Given this list of marker genes MYRF, KIF7, PPP1R15A (protein phosphatase 1 regulatory subunit 15A), TP53INP2, RELB, CLSTN3, FOS, SSTR2, C11orf87, SLC18A2, HDX, PLK4, KYAT1, PPIG, PTPRU, UBA52, NR4A2, RNF5, LETM2, PSMB8, ITFG2, GPBP1, DHX36 (NCBI Gene Id 96337), LSM12, PNMA6A, CRELD1, SYNGR3, JAG1 (jagged canonical Notch ligand 1), NUP98, MAFF, IRX3, AGPAT1 (1-acylglycerol-3-phosphate O-acyltransferase 1), SEMA4C, DUSP1, NDUFA10, WNT10A, ARL4D, RBP5, AKIRIN1, PFAS, MAP3K7, CMTR1, RAB24, HS3ST2, SLC38A1, PTGR3, TIPRL, ALKBH5, WDHD1, DAAM2, SGIP1, DNAJC9, MYL6, DDX51, CRH, RBMS2, ANK2, BTAF1, RPS29, EVX1, OXNAD1, GAK, THOC1, HNRNPA2B1, RUNDC3A, GJD2, ELMO3, TAFA1, HAS1, PABPC1, CEP57, RBBP8, SDHB, SDHAF2, FAM131A, TSC22D2, SOCS4, IRF2BPL, PSENEN, ZNF687, OSR1, ZNF367, CTCF, EIF1 (NCBI Gene Id 1963), NUP214, GPR3, CLDN7, SLC66A2, NPTX1, ATP6V0C, RAB6A, KICS2, ZBTB21, RNF44, AHI1, SNAP25, NUBPL, MBNL2, SIK1, H4C5, BNIP3L (NCBI Gene Id 9257), RPL41, INTS7, MARCHF6 (NCBI Gene Id 10299), CPSF7, ZNF184, CDX4, MMGT1, ZBTB20, ERF, CHPF, CTC1, LDHA, NR2E1, ELAVL1, NEUROD6, PAK1, RPRD1A, CD2AP, UCN, PAK3, TRIB1, RAB7A, TLNRD1, C1orf35, ELOVL5, ZZEF1, PPARGC1A (NCBI Gene Id 10891), NINJ1, TGIF2, ZC3H10, PHACTR3, ZNF516-DT, GEM, PNMA3, IRX6, TMEM147, BRAF, RAB25, EPHA2, CDK2AP2, MAP3K13, ATF3, MRGPRF, GTF2A1, SENP2, ZMYND15, GRM3, DACT1, ATG5, TRIM39, KLF13, PDP1, SLC38A2, PAFAH1B1, SARNP, ANKRD17, TEX14, KCNJ2 (potassium inwardly rectifying channel subfamily J member 2), PITX2, IFT57, ZNF593, LGR5, SCAMP5, TMEM39A, RUSC1-AS1 (RUSC1 antisense RNA 1), TMEM59L, RIPOR1, RPS6KA3, CMSS1, SLC31A1, CHGB, TMEM86A, GLYR1, LTBP1, MAP1LC3A, SREBF2, RAB3A, ING3, CDC14B, CNTROB, YTHDC2, DPH3, MSX2, SPATA7, CLCN3, PCSK1, CBX3, NR4A3, KNL1, HHIP, EGR3, TUBB2B, ABHD16A, PPM1A, ZNF711, SIDT2, U2AF1L4, CXCL16, FOSB, CYLD (CYLD lysine 63 deubiquitinase), TPM4, VPS37B, CHAC1 (NCBI Gene Id 79094), CSTF3, CCDC148, MAF (MAF bZIP transcription factor), WFDC3, EGR4, NOL4, IKBKB, FGF9, NF1, HHEX, ID1, MRRF, YJU2B, TMEM175, RUSC1, NOC4L, G3BP2, SIK2, PNRC1, SMAD1 (NCBI Gene Id 4086), SRSF1, CHMP2A, PRR3, TMUB2, PRELID1, TSC22D3, DDX3X, TAOK2, SST, LMCD1 (LIM and cysteine rich domains 1), GPM6B, NFKBID, GTF3C1, TSPAN7, FAM174A, ADCY8, CDC42, FBXL2, SLC25A37, PENK, TLE3, HOXC10, GNAS, FOXD3, IRX4, GNL1, RIPK4, FAM167A (family with sequence similarity 167 member A), CBX8, RING1, RCAN1, SCG2, CYSTM1, UBQLN2, CCN4, PKP4 (NCBI Gene Id 8502), KIF17, RAI1, OGDH, FANCD2, ORMDL2, JOSD1, PNPLA3, OSBPL9, PPP2R2A, NR6A1, ASPHD1, ING4, here is a description of the gene set: Human Gene Set: CREB_Q4 Genes having at least one occurrence of the motif NSTGACGTMANN in the regions spanning 4 kb centered on their transcription starting sites. This matches the CREB1 transcription factor binding site V$CREB_Q4 (v7.4 TRANSFAC). species: Homo sapiens